The following is a description of a gene set: species: Homo sapiens Human Gene Set: GOBP_PROTEIN_CONTAINING_COMPLEX_REMODELING The acquisition, loss, or modification of macromolecules within a complex, resulting in the alteration of an existing complex., and this is the list of marker genes: ANGPTL4, PCSK6, PNLIPRP3, ABCG1, GPIHBP1, PCSK5, PLA2G7, PLA2G3, APOA2, APOA1, AGTR1, PLA2G5, LCAT, PLA2G10, PNLIPRP2, APOA5, APOH, APOB, PON1, PLTP, PNLIP, APOE, FURIN, ABCA5, AGT, APOA4, SCARB1, NR1H4, PLA2G2A, TAF8, PLA2G2E, PNLIPRP1, ANGPTL3, LIPC, MPO, DIAPH3, APOM, LIPG, APOC3, LPL, CETP, MTTP, APOC2, APOC1